Given this list of marker genes DDX23, SF3B6, SF3B2, GTF2F2, POLR2I, NCBP2, PRPF8, ZRSR2, ZCRB1, SNRPF, DDX42, EFTUD2, POLR2B, SNRPG, SRSF2, PDCD7, SNRNP25, SRSF1, TXNL4A, POLR2E, POLR2L, GTF2F1, POLR2C, POLR2G, SNRNP35, SNRPE, POLR2K, POLR2A, SRSF7, SF3B5, SNRPD2, SNRNP48, YBX1, SNRPD1, SNRNP200, POLR2D, RNU11, SNRNP40, SNRPB, NCBP1, POLR2J, SF3B4, RNU12, RNPC3, SRSF6, SNRPD3, SF3B1, POLR2F, SF3B3 (splicing factor 3b subunit 3), RNU4ATAC, ZMAT5, PRPF6, POLR2H, here is a description of the gene set: part of: mRNA Splicing Reactome Pathway: mRNA Splicing - Minor Pathway The splicing of a subset of pre-mRNA introns occurs by a second pathway, designated the AT-AC or U12-dependent splicing pathway. AT-AC introns have highly conserved, non-canonical splice sites that are removed by the AT-AC spliceosome, which contains distinct snRNAs (U11, U12, U4atac, U6atac) that are structurally and functionally analogous to the major spliceosome. U5 snRNA as well as many of the protein factors appear to be conserved between the two spliceosomes. studied in species Homo sapiens